The following is a description of a gene set: electronically inferred by orthology from the curated human pathway This event has been computationally inferred from an event that has been demonstrated in another species.<p>The inference is based on the homology mapping from PANTHER. Briefly, reactions for which all involved PhysicalEntities (in input, output and catalyst) have a mapped orthologue/paralogue (for complexes at least 75% of components must have a mapping) are inferred to the other species. species: Mus musculus part of: TRAF6 mediated induction of NFkB and MAP kinases upon TLR7/8 or 9 activation Reactome Pathway: IRAK1 recruits IKK complex upon TLR7/8 or 9 stimulation, and this is the list of marker genes: Peli2, Ube2v1, Ubb, Ube2n, Irak1, Rps27a, Ikbkb